Given this list of marker genes B3galnt2, Pomk, Pomt1, Pomt2, Dag1, here is a description of the gene set: studied in species Mus musculus Reactome Pathway: DAG1 core M3 glycosylations electronically inferred by orthology from the curated human pathway part of: DAG1 glycosylations This event has been computationally inferred from an event that has been demonstrated in another species.<p>The inference is based on the homology mapping from PANTHER. Briefly, reactions for which all involved PhysicalEntities (in input, output and catalyst) have a mapped orthologue/paralogue (for complexes at least 75% of components must have a mapping) are inferred to the other species.